Given this list of marker genes HSD17B13, KCNIP3, PCDHGA9, PCDHGA12, SLC25A21, THSD4 (thrombospondin type 1 domain containing 4), SMG1 (NCBI Gene Id 23049), ZNF84, DGKK, PSMA5, FOXC1, IMPG1, KMT2A, LIX1L, CCDC62, IRX2-DT, RER1, PCDHGA11, PCDHGB7, P2RX2, ATG12, PCDHGA8, PCDHGA7, ELK4, RAB26, GIPC2, CCL11, GLO1, ENOPH1, PCDHGA2, ATF2, ENPP1, C16orf46, AHSA1, ZFPM2, ZNF705EP, PCDHGC3, ZNF706, BCL2L11, KLHL15, ZHX1, DAAM1, PCDHGA5, STAM2, ACLY, URI1, PCDHGA1, TCL1B, ELOVL6, RIOX2, LIN54, SLC4A10, PCDHGB3, AGAP1, PCDHGA10, TPM1, CNOT6L, NKAP, PCDHGA3, ZNF705A, EXO5, DEPDC4, MSL2, ELAVL2, MSR1, SPTLC2, WSB2, C10orf105 (chromosome 10 open reading frame 105), PDK3, SCRT2 (scratch family transcriptional repressor 2), HCLS1, here is a description of the gene set: from publication Chen Y, Wang X (PMID 31504780) Genes predicted to be targets of miRBase v22 microRNA hsa-miR-4740-5p in miRDB v6.0 with MirTarget v4 prediction scores > 80 (high confidence targets). Human Gene Set: MIR4740_5P studied in species Homo sapiens